The following is a description of a gene set: studied in species Mus musculus Mouse Gene Set: GOBP_POSITIVE_REGULATION_OF_UBIQUITIN_PROTEIN_LIGASE_ACTIVITY Any process that activates or increases the frequency, rate or extent of ubiquitin protein ligase activity., and this is the list of marker genes: Fzr1, Btrc, Ube2srt, Pten, Cdc20, Cdc14b, Skp1, Ube2s, Plk1, Mastl